The following is a description of a gene set: studied in species Homo sapiens Enables the transmembrane transfer of a calcium ion by a voltage-gated channel across the plasma membrane of a cardiac muscle cell that contributes to the depolarization phase of an action potential. A voltage-gated channel is a channel whose open state is dependent on the voltage across the membrane in which it is embedded. Human Gene Set: GOMF_VOLTAGE_GATED_CALCIUM_CHANNEL_ACTIVITY_INVOLVED_IN_CARDIAC_MUSCLE_CELL_ACTION_POTENTIAL, and this is the list of marker genes: CACNA1C, CACNB2, CACNA1D, CACNA2D1, CACNA1G